Given this list of marker genes Snapc1, Ice1, Snapc5, Cc2d1a, Snapc4 (small nuclear RNA activating complex, polypeptide 4), Ell, Zc3h8, Snapc3, Ell3, Myod1, Mepce, Ell2, Ice2 (NCBI Gene Id 93697), Larp7-ps, Larp7, here is a description of the gene set: The synthesis of small nuclear RNA (snRNA) from a DNA template by RNA Polymerase II (Pol II), originating at a Pol II promoter. Mouse Gene Set: GOBP_SNRNA_TRANSCRIPTION_BY_RNA_POLYMERASE_II species: Mus musculus